Given this list of marker genes RAP1GDS1, TMCO1, BCL2, DMTN, PML, CCDC47, HERPUD1, ATP2A1, THADA, ATP2A2, SELENOK, BAK1, TUNAR, KCTD17, CLCC1, ITPR1, TMTC4, BAX, PACS2, CAMK2D (calcium/calmodulin dependent protein kinase II delta), WFS1, GRINA, TMBIM6, PSEN1, KCNK16, TGM2, here is a description of the gene set: Human Gene Set: GOBP_ENDOPLASMIC_RETICULUM_CALCIUM_ION_HOMEOSTASIS species: Homo sapiens Any process involved in the maintenance of an internal steady state of calcium ions within the endoplasmic reticulum of a cell or between the endoplasmic reticulum and its surroundings.